The following is a description of a gene set: Binding to monomeric or multimeric forms of actin, including actin filaments. Human Gene Set: GOMF_ACTIN_BINDING studied in species Homo sapiens, and this is the list of marker genes: PRICKLE4, HIP1, NF2, CORO1A, TMSB4Y, FHDC1, MYBPC1, COBLL1 (NCBI Gene Id 22837), LCP1, MYO6, TNNI1, DYRK1A, MYO1H, SSH3, HNRNPU, PPP1R9A, TRPM7, MED28, CAP2, PDLIM7, GAS2L2, PACRG, SPTA1, SLC6A4, ARHGAP27, MYH15, LIMS1, MICAL1, TWF2, GCSAM, TPRN, WAS (NCBI Gene Id 7454), MYO1E, TMEM201, TMSB4X, ACE, SYNE2, NEB, FSCN3, MACF1, CLASP2, SHROOM1, PPP1R9B, EPS8, VASH2, FMN1, KLHL2, MYO7B, WASHC1, SPTB, LIMCH1, ACTR3C, SORBS1, CNN2, CYFIP1, KLHL1, EPS8L3, PANX1, MSRB1, MYLK (NCBI Gene Id 50483), SYNPO2L, PPP1R18, FMNL3, MYH7, WASF2, TNNT2, CAMSAP3, SAMD14, CEACAM1, INO80, SYNPO2, PHACTR1, VPS18, P4HB, TNS1, CAPG, HOMER2, SCIN, MYO1C, HOOK1, ALKBH4, ESPNL, MSRB2, PRKCE, HPCA, MPRIP, SHTN1, PICK1, MYO9A, MARCKSL1, VASH1, GBP1, SVIL (supervillin), ARPC5L, TRPC5, MYBPC3, PTK2, WASF3, INF2, PARVG, MYO1B, MICALL2, KPTN, TLN1, TNS4, MYH10, CROCC, TMOD3, TMSB15A, MYH6, SPEF1, FMNL2, DAAM2, SNCA, FMNL1, MYO5C, TMOD2, EPS8L2, EPB41, PARVB, ABLIM3, SPATA32, ABITRAM, FRG1, DIAPH2, TAGLN3, PLEKHH2, HDAC6, PRKN, CALD1, MYO1A, FERMT1, FERMT2, DST, NRAP, INPPL1, SPTBN4, HDGF, CORO2A, SETD3, CORO1B (coronin 1B), WASH6P, BAIAP2L1, TPM3, SNTB2, SNTA1, MYO7A, ERMN, ANLN, FAM107A, MAP1S, NEBL, PFN2 (NCBI Gene Id 85837), PPP1R42, FSCN1, MIB2, TULP1, RUSC1, DBNL, AFAP1, EVL, ITGB1, MYO9B, PDLIM1, MISP, CAMK2B, SNTG1, CAPZA2, BIN1, STK38L, GMFG, IQGAP3, SHROOM4, EEF2, CTNNAL1, LRPPRC, MYL3, GJB6, WDR1, TLNRD1, MICAL3, MYO3B, MYO18A, CTNNA3, SHROOM2, FBXO25, SPTBN1, KCNMA1, ARPC1A, MAP1B, ESPN (NCBI Gene Id 83715), MYOZ2, TAGLN, FLII, COBL, TNNI2 (troponin I2, fast skeletal type), XIRP1, MYH11, BLOC1S6, WASL, FHL3, BCL7B, TRIOBP, EZR (ezrin), ADD2, EPS8L1, GC, IPP, MYBPC2, MAP1A, WIPF3, GMFB, CNN3, MYO19, IMPACT, GAS2L3, CDK5R1, ANG, EPB41L2, LIMA1, SLC6A2, MYH2, DIAPH1, CTNNA1, LUZP1, TPM2, PLEC, PFN3, DIAPH3, ACTR3B, RCSD1, MYOT, IQGAP1, MYH4, VIL1, TMSB10, DAG1, ARPC5, HIP1R, TMOD1, MYOZ3, CORO1C, SPTBN5, MYH7B, FXYD5, PXK, MYO15A, CTNNA2, DSTN, WASH3P (WASP family homolog 3, pseudogene), MYO16, DAAM1 (dishevelled associated activator of morphogenesis 1), CCR5, SYNPO, ADD1, ANKRD35, KLHL3, PARVA, CD2AP, CACNB2, TNNC2, SPTAN1, CAPZA1, KBTBD13, VILL, VPS16, LMOD3, MARCKS, LASP1, JMY, ABLIM1, ADD3, MYO1G, GAS2, CLMN, ARPC3, AMOTL2, NOS3, UTRN, PDLIM5, FKBP15, MTSS2 (NCBI Gene Id 92154), CORO2B, MYO1F, FLNB, MYO18B, MYH13, TNNC1, UACA, CFL1, CORO7, ENC1, MICAL2, PDLIM3, MYO10, FMN2, DIXDC1, ACTN1, PAWR, MRTFA, OPHN1, PHACTR2 (NCBI Gene Id 9749), MEFV, CAP1, ACTR3, ACTR2, CCDC88A, COTL1, SSH2, TNNI3, MAPT, ADCY8, TRPC6, TPM4, ACTN3, TMSB15C, MYH1, TLN2, LMOD1 (leiomodin 1), MSN, TMOD4, KLHL17, PLEKHG3, AVIL, RAI14, HCLS1, EPB41L3, PALLD, LRRC10, PKNOX2, MYL2, CGN, TAGLN2, KLHL5, CDK5R2, CORO6, FHOD1, ARPC4, PFN1, FSCN2, IQGAP2, AFDN, NOD2, MLPH, TPM1, PDLIM2, VCL, KLHL20, DNASE1, MYH9, CXCR4, ANXA8, ABI3, TMSB15B, S100A4, MYL4, GAS2L1, ANKRD24, VASP, MYRIP, MYPN, LMOD2, AIF1, PHPT1, MYH14, DBN1, MYO3A, ABLIM2, TTN (titin), WIPF2, NCALD, ACTN2, CSRP3, LSP1, SMTN, CAPZA3, DMTN, FLNC, XIRP2, ABRA, SPIRE2, SNTG2 (NCBI Gene Id 728185), DMD, ADSS1, PLS1, LRRK2, PLS3, PHACTR4, KIF18A, ITPRID2, MTSS1, ARPC2, FGD4, SPTBN2, MYOZ1, PDLIM4, UXT, AIF1L, WASF1, MYO5B, ARPC1B, PFN4, YWHAH, SYN1, ABL2 (ABL proto-oncogene 2, non-receptor tyrosine kinase), PIP, ACTN4, POF1B, WIPF1, SHROOM3, LIMD2, SPIRE1, GIPC1, GSN, MYO5A, LDB3, MAEA, ABL1, TRPV4, SHANK3, TBC1D21, TNNT3, RDX, FHOD3, MYH3 (NCBI Gene Id 4621), EPB41L1, ENAH, SNTB1, PHACTR3, MYH8, EMD, MYO1D, CAPZB, NEXN, EGFR, TWF1, CNN1, FLNA, CFL2, SYNE3, KLHL4, ANTXR1, AJUBA, SYNE1, ALDOA (NCBI Gene Id 226), WHAMM, SSH1